The following is a description of a gene set: part of: MAPK family signaling cascades Reactome Pathway: MAPK1/MAPK3 signaling This event has been computationally inferred from an event that has been demonstrated in another species.<p>The inference is based on the homology mapping from PANTHER. Briefly, reactions for which all involved PhysicalEntities (in input, output and catalyst) have a mapped orthologue/paralogue (for complexes at least 75% of components must have a mapping) are inferred to the other species. electronically inferred by orthology from the curated human pathway species: Mus musculus, and this is the list of marker genes: Csf2rb, Brap, Fgf10, Csk, Nrg3, Kl, Fgf2, Psmb7, Fgg, Artn, Cnksr2, Btc, Pdgfa, Ptpn3, Il5, Fnta, Sptbn2, Tgfa, Rasal3, Fgfr1, Il6, Ppp5c, Il2ra, Zdhhc9, Psmc6, Ranbp9, Ptpn7, Grin1, Psmb6, Frs2, Grin2b, Erbb4, Psma1, Ppp2r5a, Rasgrp1, Rapgef2, Mapk12, Ubb, Rasgef1a, Psmc1, Ncam1, Lamtor2, Irs1, Rgl3, Shc3, Dusp16, Pik3cb, Cnksr1, Psmb4, Fgf17, Grb2, Fgf23, Sptbn4, Psmd7, Psma3, Lat, Psmc2, Psma7, Il2, Jak3, Psma6, Nrtn (neurturin), Pdgfrb, Pebp1, Epgn, Shoc2, Dusp7, Irs2, Fyn, Ksr2, Arrb2, Gfra2, Itga2b, Hras, Ret, Psmc4, Fgf6, Fgf15, Psmd1, Fgf8, Ptpra, Hgf (NCBI Gene Id 15234), Dlg3, Erbb2, Pik3r2, Tln1, Il2rb, Kitl, Dusp9, Bcl2l1, Klb, Rasgrp3, Pdgfb, Ppp2r1b, Dusp5, Grin2d, Psma5, Ralgds, Tyk2, Psma2, Psmd12, Flt3l, Dusp6, Lypla1, Il6ra, Rps27a, Il3, Shc1, Spred3, Fgf22, Csf2, Camk2b, Rasa1, Nefl, Rgl1, Apbb1ip, Map2k2, Il5ra, Phb1, Abhd17c, Egfr, Kit, Fgf16, Areg, Shc2, Psmc3, Dusp2, Psmb5, Fgf20, Rasa4, Dlg4, Ptk2, Psmd6, Calm1, Mapk3, Pea15a, Map2k1, Ppp2r5b, Psmc5, Ppp2r5d, Fgf1, Rasgrp4, Il2rg, Fgf4, Gdnf, Cdk1, Gfra1, Fgf7, Fgf5, Psma4, Wdr83, Psmd13, Rasal1